Given this list of marker genes Dusp22, Myh14, Lztr1, Myc, Blnk, Arfip2, Slpi, Gne, Ube2t, Klra17, Pvr, Bsg, Cilk1, Psmb3, Extl2, Eif4a1, Nol8, Agr2, Matk, Pigk, Mybbp1a, Maged1, Mfap2, Ipo4, Arhgap8, Etv4 (ets variant 4), Srp9, Skil, Fstl1, Vegfa, Snd1, Lypd3, Usf1, Ddost, Clip1, Lbp, Inhbb, Eef1a2, Timp1, Lyve1, Loxl4, Xbp1, Sec61a1, Park7, Enpep, Mageh1, Nol3, Col6a2, Pdgfra, Rgsl1, Col5a2, Chst1, Ptgis, Kat2a, Ganab, Ctsw, Igfbp3, Epcam, Nectin4, Basp1, Prmt7, P4hb, Aebp1, Farp2, Bmp1, St14, Ppp2r5a (protein phosphatase 2, regulatory subunit B', alpha), Sec63, Mmp2, P4ha2, Stat2, Itgb5, Lamc2, Calu, Wasl, Stt3a, Cytip, Epas1, Rnf25, Figla (NCBI Gene Id 26910), Col4a2, Med29, Col1a1 (collagen, type I, alpha 1), Tbrg4, C1qbp, Csnk1e, Senp2, Trip6, Rabggta, Ajuba, Svil, Alpl, Spon1, Sparcl1, Ccl11, Trib1, Lamb1, Dnajb11, Uchl5, here is a description of the gene set: from publication Qi CF, Zhou JX, Lee CH, Naghashfar Z, Xiang S, Kovalchuk AL, Fredrickson TN, Hartley JW, Roopenian DC, Davidson WF, Janz S, Morse HC 3rd (PMID 17363561) Mouse Gene Set: QI_PLASMACYTOMA_DN species: Mus musculus Down-regulated genes that best disciminate plasmablastic plasmacytoma from plasmacytic plasmacytoma tumors. We have compared histologic features and gene expression profiles of newly identified plasmacytomas from NFS.V(+) congenic mice with plasmacytomas of IL6 transgenic, Fasl mutant, and SJL-beta2M(-/-) mice. NFS.V(+) tumors comprised an overlapping morphologic spectrum of high-grade/anaplastic, intermediate-grade/plasmablastic, and low-grade/plasmacytic cases with similarities to subsets of human multiple myeloma and plasmacytoma. Microarray and immunohistochemical analyses of genes expressed by the most prevalent tumors, plasmablastic plasmacytomas, showed them to be most closely related to immunoblastic lymphomas, less so to plasmacytomas of Fasl mutant and SJL mice, and least to plasmacytic plasmacytomas of IL6 transgenic mice. Plasmablastic tumors seemed to develop in an inflammatory environment associated with gene signatures of T cells, natural killer cells, and macrophages not seen with plasmacytic plasmacytomas. Plasmablastic plasmacytomas from NFS.V(+) and SJL-beta2M(-/-) mice did not have structural alterations in Myc or T(12;15) translocations and did not express Myc at high levels, regular features of transgenic and pristane-induced plasmacytomas. These findings imply that, as for human multiple myeloma, Myc-independent routes of transformation contribute to the pathogenesis of these tumors. These findings suggest that plasma cell neoplasms of mice and humans exhibit similar degrees of complexity. Mouse plasmacytomas, previously considered to be homogeneous, may thus be as diverse as their human counterparts with respect to oncogenic mechanisms of plasma cell transformation. Selecting specific types of mouse plasmacytomas that relate most closely to subtypes of human multiple myeloma may provide new opportunities for preclinical testing of drugs for treatment of the human disease.